Given this list of marker genes CES1, EHD1, ABCA1, NR1H3, LPL, NPC1, STARD4, TREM2, APOB, NR1H2, MIR144, NPC2, SREBF2, LIPA, SCARB1, PPARG, CD36, PPARD, TTC39B, PPARA, MIR146A, MSR1, SOAT1, SOAT2, ABCG1, here is a description of the gene set: Human Gene Set: GOBP_CHOLESTEROL_STORAGE The accumulation and maintenance in cells or tissues of cholesterol, cholest-5-en-3 beta-ol, the principal sterol of vertebrates and the precursor of many steroids, including bile acids and steroid hormones. species: Homo sapiens